The following is a description of a gene set: Any process that modulates the frequency, rate or extent of long term synaptic depression. species: Mus musculus Mouse Gene Set: GOBP_REGULATION_OF_LONG_TERM_SYNAPTIC_DEPRESSION, and this is the list of marker genes: Pirb, Adcy8, Gnal, Fmr1, Ager, Sorcs3, Dgki, Stau2, Grid2, Cbln1, Shank3, Mapt, Bcl2l1, Kcnb1, Iqsec2, Adora1, Penk, Ppp1r9a, Arc